The following is a description of a gene set: Human Gene Set: GOBP_PROTEIN_NEDDYLATION Covalent attachment of the ubiquitin-like protein NEDD8 (RUB1) to another protein. studied in species Homo sapiens, and this is the list of marker genes: COPS6, DCUN1D2, DCUN1D5, CDKN2A, RNF7, UBE2F, COPS8, RBX1, COPS9, RPL5, DCUN1D3, TRIM40, COPS7B, DCUN1D4, COPS2, COPS3, COPS4, DCUN1D1, COPS5, NAE1 (NEDD8 activating enzyme E1 subunit 1), EPAS1, RPL11, UBA3, HIF1A, UBE2M, COPS7A, NEDD8, GPS1